Given this list of marker genes Rpa1, Rfc1, Rfc5, Isy1 (NCBI Gene Id 76060), Pole, Polr2c, Gtf2h5, Polr2a, Prpf19, Ercc2, Rfc4, Uba52, Ubb, Ercc4, Rps27a, Gtf2h1, Pcna, Ercc8, Polk, Polr2i, Cul4b, Pold1, Gtf2h3, Pole2, Usp7, Xpa, Pold2, Polr2l, Cdk7, Polr2b, Tcea1, Polr2k, Pole4, Uba52rt, Polr2d, Polr2h, Xab2, Ccnh, Ddb1, Polr2f, Ercc5, Gtf2h4, Zfp830, Uvssa, Gtf2h2, Ercc1, Rbx1, Pole3, Rpa3, Polr2e, Ercc3, Mnat1, Cul4a, Ubc, Aqr, Rfc3, Pold3 (NCBI Gene Id 97395), Ercc6, Pold4, Rfc2, Rpa2, Polr2g, here is a description of the gene set: studied in species Mus musculus Dual incision in TC-NER Mouse Gene Set: REACTOME_DUAL_INCISION_IN_TC_NER